The following is a description of a gene set: Human Gene Set: GOBP_REGULATION_OF_ADHERENS_JUNCTION_ORGANIZATION Any process that modulates the frequency, rate or extent of adherens junction organization. species: Homo sapiens, and this is the list of marker genes: VEGFA (NCBI Gene Id 7422), PTPN23, RDX, ADD1, BMP6